The following is a description of a gene set: species: Mus musculus Mouse Gene Set: GOBP_RESPONSE_TO_PURINE_CONTAINING_COMPOUND Any process that results in a change in state or activity of a cell or an organism (in terms of movement, secretion, enzyme production, gene expression, etc.) as a result of a purine-containing compound stimulus., and this is the list of marker genes: Trpc3, Zfp36l1, Gata1, Ryr3 (NCBI Gene Id 99099), Pck1, P2rx5, Hcn2, Igfbp5, Bsg (basigin), Pde3a, Adss2 (adenylosuccinate synthase 2), Crem, Thbd, Ass1, P2rx3, Pygm, Kcne1, Pklr, Rap1a, Creb1, Rapgef1, Itpr3, Cib2, Rapgef3, Inhbb, Kcnj8, Ptgs2, Pnpt1, Crhbp, Aanat, Selenon, Panx1, Areg, Sdc1, Itpr2, Cps1, Pde2a, Ezr, Slc6a3, Pfkfb1, Fkbp1a, Bckdhb, Itpr1, Hmgcs1, P2rx7, Pdxp, Hmgcs2, Duox1, Npr2, Hcn1, Irs1, Ptk2b, Tmem38b, Pik3cg (NCBI Gene Id 76039), Lncbate10, Akap6, Cnga3, Fos, Sell, Ryr1, Rela, Oxt, Agxt, Fosl1, Trpm4, Dmtn, Hsp90b1, Dntt, Gata6, Slc26a3, Plcg2, Ada, Adora1, Fdx1 (ferredoxin 1), Cyp27b1, Casq2, Ren1, Aqp1, Pkd2, Ndufs4, Mat2a, Rplp0, Inpp5k, Rap1b, Gnal, Tyr, Trpm2, Il1b, Kdm1a, Ryr2 (ryanodine receptor 2, cardiac), Atf1, P2rx4, Hmga1, Adora2a, Gstm7, Tlr7, Rapgef2, Penk, Nt5e, Hcn4, Prss2, Carm1 (NCBI Gene Id 59035), Ptafr, Ssh1, Aqp8, Casp1, Vgf, Cyp1b1, P2ry12, Adipoq, Star, Col1a1, Pax4, Aldh3a1, Abcc9, Wnt10b, Slc6a1, Birc2, Slc26a6, Stc1, Cdk2, Prkaa1, Fbp1, Slc6a4, Cad, Ins1, Crtc1, Ahr, Akap7, P2rx1, Ccl2, P2rx2, Pde4d, Tmem38a, Cacna1s, P2ry1, Slc8a1, Prkaa2, Cdo1, Crtc3 (CREB regulated transcription coactivator 3), Crtc2, Kcnj11, Chek1, P2ry6, Mmp19, Gpd1, Slc8a3, P2rx6, Fosb, Cftr, Stat1, Braf, Akap9, Cited1, Eef2k, Per1 (NCBI Gene Id 18626), Dgkq (diacylglycerol kinase, theta), Pik3r1, Duox2, Asph, Trpv1, Kcnq1, Srebf1, Top2b